The following is a description of a gene set: studied in species Homo sapiens Human Gene Set: GOBP_OSTEOBLAST_DEVELOPMENT The process whose specific outcome is the progression of an osteoblast over time, from its formation to the mature structure. Osteoblast development does not include the steps involved in committing a cranial neural crest cell or an osteoprogenitor cell to an osteoblast fate. An osteoblast is a cell that gives rise to bone., and this is the list of marker genes: GLI2, RUNX2, SHH, MSX2, PTHLH, JUND, HOXA2, SATB2, ACHE, LIMD1, LRP5, CLEC5A, MEN1, CEBPA, PTH1R, SMAD3, TNN, BGLAP